The following is a description of a gene set: species: Homo sapiens Catalysis of the reaction: a monoacylglycerol + H2O = a fatty acid + glycerol + H+. Human Gene Set: GOMF_MONOACYLGLYCEROL_LIPASE_ACTIVITY, and this is the list of marker genes: ABHD16B, ABHD15, PNLIPRP2, DAGLB, FAAH, ABHD12, DAGLA, ABHD12B (NCBI Gene Id 145447), ABHD1, LIPE, ABHD2, MGLL, ABHD16A, ABHD6, ABHD3